The following is a description of a gene set: Genes up-regulated in dendiritic cells from speen: interferon producing killer cells versus conventional. Human Gene Set: GSE3691_IFN_PRODUCING_KILLER_DC_VS_CONVENTIONAL_DC_SPLEEN_UP from publication Chan CW, Crafton E, Fan HN, Flook J, Yoshimura K, Skarica M, Brockstedt D, Dubensky TW, Stins MF, Lanier LL, Pardoll DM, Housseau F (PMID 16444266) species: Homo sapiens To characterize differences between BALB/c splenic CD11cintB220+Gr1+ PDCs (plasmacytoid dendritic cells), CD11cintB220+CD49b+ IKDCs (interferon producing killer-dendritic cells), and CD11chighB220- cDCs (conventional dendritic cells), we performed gene expression profile analysis using Affymetrix chips. We FACS-sorted BALB/c spleen DC subpopulations. Comparison of differentially expressed genes between IKDCs and cDCs vividly revealed selective expression of multiple NK-related genes in IKDCs. These included granzymes A, B, K and M, perforin, Fas ligand, and NK receptors such as NKG2A, NKG2D, Ly49 family genes, NKR-P1, NKG7, NKp46 and Mafa (KLRG1). No NK-related genes were highly expressed in the PDCs., and this is the list of marker genes: IGFBP4, STK38L, AKTIP, EMP1, STON1, AKR1E2, CREBRF, CLCN6, SF3B1, TTC14, SMAD7, TMEM50A, RDH12, FAM193B, WFS1, ARSA, ST7L, IP6K1, CSPP1, IFT52, TEAD1, GAREM1, B3GNT8, DDB2, ACADM, TGFBR1, CAPNS1, ANKRD12, TRAK1, FHL3, ZNF236, CNIH1, TEC, GPRASP1, C12orf57, VPS28, NSMF, RNF130, NME4, STEEP1, DENND1A, RIMOC1, MAP4K4, DNAJB4, ETFBKMT, ARHGAP24, CFAP418, SMIM19, NRARP, PARVG, MAF, OAZ2, RPRD1A, STX6, ATRN, TMC5, CEP83-DT, MAP4K2, TMEM167B, CLCF1, MPZL1, BSDC1, CCT6B, DIP2B, ITPR3, MEAK7, SMAD1, CHD2, RMND5A, ETFDH, GTF2IRD1, ABHD14B, STX4, NBR1, ACTR3B, OXR1, CPLANE1, MRPL14, SAPCD1, IRF6 (interferon regulatory factor 6), MIDEAS, GOLGA1, FBXO6, USP22, RAB18, GALNT11, MEX3C (NCBI Gene Id 51320), DBP (NCBI Gene Id 1628), B4GALT1, IKZF4, GM2A, NR3C1, MAP4, CD68, ZDHHC17, TECPR1, ATXN7, BAHD1, LRRC28, ENSG00000267882, PLCG1, TRIM24, FAM210B, ATP1B1, MTMR1, TLR2, PRAMEF8, TBL1XR1, B9D2, SEPTIN6, TEP1, STAC3, PPOX, IKZF3, RAB37, MPP1, PFKFB4, SLC17A7, ENSA, PWWP2B, GPX8, MYOF, GPR137, MDM4, ARMC10, ZFP90, RCOR3, CABLES1 (Cdk5 and Abl enzyme substrate 1), CEP97, MLANA, CTSW, HBP1, DGAT2, ANP32A, PRDX2, DHRS7, MAGED1, DDX4, NNT, TTBK2, SNORD89, ABITRAM, ACOX1, ST3GAL2, VPS26B, PATJ, ZFAND6, PHKA2, EPB41L2, SMOX, N4BP1 (NEDD4 binding protein 1), SERINC5, RFXANK, ACOT9, SPATA7, ENTREP3, ATG12, HTT (huntingtin), NUPR1, EIF3H, ENDOV, ARSK, SNX32, PIK3C3, MAPK9, CLK4, ATAT1, CEP95, NCK1 (NCBI Gene Id 4690), NPC1, FAM78A, ARFIP1, TMED4, BCKDHA, FFAR4, TSC22D3, SPATA1, KLHL24, INPP5F, PRKCG, IFT140, DNAAF9, TSPO, PARD6G, LGALS8, GAPVD1, FBXW4, IL27RA, NIN (NCBI Gene Id 57681), USF3, PON3, MBIP, SLC36A1, SCARB2, NTAQ1, MICAL2, PI4K2A, IFNGR1, SARDH, FAM98C